The following is a description of a gene set: Human Gene Set: GOBP_INTERNAL_PROTEIN_AMINO_ACID_ACETYLATION species: Homo sapiens The addition of an acetyl group to a non-terminal amino acid in a protein., and this is the list of marker genes: BAG6, ATAT1, KAT2A, EP300, KAT2B, HAT1, NAA10, NAT8B, NAT8, KAT7